The following is a description of a gene set: species: Homo sapiens from publication Chen Y, Wang X (PMID 31504780) Genes predicted to be targets of miRBase v22 microRNA hsa-miR-6761-5p in miRDB v6.0 with MirTarget v4 prediction scores > 80 (high confidence targets). Human Gene Set: MIR6761_5P, and this is the list of marker genes: CYB5B, OPALIN, ALDH6A1, CHP1, TAGAP, OPRM1, STK39, FBN1, TXLNA, GSPT1, MTMR14, TRIAP1, ZNF425 (zinc finger protein 425), TRIM56, SEC14L1, CYP8B1, FKBP15, ADIPOR2 (NCBI Gene Id 84751), ATP6V1G3, BSDC1, SORCS2, NAA15, BTLA, ERLEC1, CACNA1G, GRIA3, MAPK1IP1L, TMEM154 (transmembrane protein 154), NPTX1, ADA2, NKD1, GPATCH2L, ZDHHC15, PRKAR2A, ATF3, AK4, HMBOX1, SLC41A1, TRIM6, SUPT3H, KCNIP1, CCM2, WDR26, SMG7, ESRRG, CHRM5, ATRN, IWS1, LANCL1, GABRR2, PER2, DPY30, PPP1R7, PPTC7, SLC4A8, MCC (NCBI Gene Id 4163), MARCHF6, HS2ST1, NETO2, ATAD2B, MYO1B, SLITRK3, EPSTI1, MAP3K9, GP1BB, AR, UNC5C, KLF12, TTC17, NEXMIF, PSEN1, KLF9, CCND2, PHF20L1, TGFBI, ARPC5, CBLB, BIN1, CSTF2, DACT1, SNX30, RBFOX2, PRMT8, GHDC, TMCC1, TSPAN9, CUL3, TRIM48, MMD, SHANK2, ALG14, JPH4, GPR173, PLEKHG1, RHOQ, TMEM50B, STAT5A, DPM2, RICTOR (NCBI Gene Id 253260), MAP2K6, BTD, WNT7A, ASCC1, CCDC97, SLC9A5, ELK1, CDK6, CEP70, DPP10, THSD7B, ZSCAN29, KRTAP4-6, MBTD1, TRIM66, SYT17, GRM7, RMI2